The following is a description of a gene set: Dissolution of Fibrin Clot Human Gene Set: REACTOME_DISSOLUTION_OF_FIBRIN_CLOT studied in species Homo sapiens, and this is the list of marker genes: SERPINF2, PLAU, ANXA2, PLAUR, SERPINE1, SERPINB6, SERPINE2 (NCBI Gene Id 5270), S100A10, PLAT, HRG, SERPINB2, SERPINB8, PLG